The following is a description of a gene set: A reduced degree of motion of the muscles beneath the skin of the face, often associated with reduced facial crease formation. Hypomimic face species: Homo sapiens Human Gene Set: HP_HYPOMIMIC_FACE, and this is the list of marker genes: CC2D1A, SLC39A14, PRDX3, JAM2, VPS35, RRM2B, SLC18A2 (NCBI Gene Id 6571), DNAJC6, TECPR2, EIF4G1, DNAJC13, SPR, PLA2G6 (phospholipase A2 group VI), CLTC, TXNL4A, POLG2, LRRK2, ATCAY, SNCA, MYMX, FBXO7, ATP13A2, GBA1, GIGYF2, SYNJ1, SLC6A3, POLG, SLC25A4, PLAA, KCNK9, ATP1A3, PODXL, ATP6AP2, TWNK, DDHD2, SLC30A10, CNTNAP1, FTL